Given this list of marker genes MYO1B, CHRNA1, NPDC1, IKZF4, IKBKB, TNFRSF10A, HERPUD1, RHOU, SNRPB, MT2A, KLF7, PLAT, REPIN1, FZD5, IGHG1, TBL1X, BOP1, RNF19B, RABGEF1, CRYL1, FOXA1, RIMKLB, IL1RN, HDC, BLNK, SAG, FGF11, PIK3R1, PARP4, EBF3, DSCAM, MAP3K8, NR3C1, SDS, ADIG, LAD1, S1PR3, FBXL3, DPF1, SQSTM1, IGSF6, MKI67, G6PC1, IL17RA, KRT2, EXT1, HNRNPLL, ITIH3, KCNK1 (potassium two pore domain channel subfamily K member 1), CH25H, PUF60, PTGS2, P2RY14, HOXB1, IL36A, MCOLN2, HMGB4, E2F5, RPS6KL1, HAND2, TNFRSF19 (NCBI Gene Id 55504), EPHX2, EBI3 (Epstein-Barr virus induced 3), CRYBA4, EIF3J, PDE6G, RCSD1, KRT1, APAF1, EPHA2, CYP11A1, IL36G, SH3TC1, RHOB, ATP2B2, CHST14, NFKBIZ, SAA2, IL12B, ERRFI1, ACOT1, ADSS2, HILPDA, CD81, TOP1 (DNA topoisomerase I), AMBP, RBM4B, SHC1, ITGBL1, PPP2R3A, SRGAP2, TMEM39A, MNS1, IL1RAP, HOXD1, SERPINB9, NKX2-2, KIF2C, TAX1BP1, NFKB1, PLAC9, PLPPR2, TCF21, PLEKHG5, JPH1, TSSC4, RNF2 (NCBI Gene Id 6045), DRD3, RAD23B, ADAM12, TMEM243, SEC61G, ICAM5, MEF2A, ARHGEF3, CRMP1, PLAGL2, EFEMP1, ATP6V1H, POLA2, TIE1, ACTL7A, FST, PLCL2, PROX1, SHBG, PTPRG, FPR2, THBS1, GSPT1, SYT4, MGAT3, PLXNA3, GPR84, NFKBIB, TYMS, GRHPR, TSC22D1, CWH43, MET, PHLDA2 (NCBI Gene Id 7262), GLIS1, GTF2B, MPZL2, RRAS2, FJX1, ACTA1, IL9 (NCBI Gene Id 3578), PELO, POU3F3, SHD, BRI3, CHD1, IFNA1, HELQ, DTNB, ABLIM1, CHID1, ATP8B3, SOX9, GAD1, SLC12A4, DUSP16, MAML2, LAG3, RPS6KA2, THOC2, MMD, DUSP2, BET1L, UBXN10, AP2B1, CTSF, MAP2 (microtubule associated protein 2), PTBP1, COL4A6 (collagen type IV alpha 6 chain), NSG2, TPP2, DNAJB12, BLOC1S4, HSP90AA1, USP9X, PDX1, EML3, PRKD1, AMHR2, BCL10, C2orf76, SFMBT2, AP4B1, GPR85, WDR48, DYM, ERAS, DCBLD2, MARCKS, RAB32, EDN1 (NCBI Gene Id 1906), SOCS4, MFSD6, here is a description of the gene set: studied in species Homo sapiens Genes down-regulated in comparison of dendritic cells (DC) stimulated with poly(I:C) (TLR3 agonist) at 2 h versus DC cells stimulated with Pam3Csk4 (TLR1/2 agonist) at 2 h. mouse primary BMDCs were stimulated with tlr ligands and gene expression changes were profiled on Affymetrix arrays Human Gene Set: GSE17721_POLYIC_VS_PAM3CSK4_2H_BMDC_DN from publication Amit I, Garber M, Chevrier N, Leite AP, Donner Y, Eisenhaure T, Guttman M, Grenier JK, Li W, Zuk O, Schubert LA, Birditt B, Shay T, Goren A, Zhang X, Smith Z, Deering R, McDonald RC, Cabili M, Bernstein BE, Rinn JL, Meissner A, Root DE, Hacohen N, Regev A (PMID 19729616)